The following is a description of a gene set: Alveolar rhabdomyosarcomas (ARMS) are aggressive soft-tissue sarcomas affecting children and young adults. Most ARMS tumors express the PAX3-FKHR or PAX7-FKHR (PAX-FKHR) fusion genes resulting from the t(2;13) or t(1;13) chromosomal translocations, respectively. However, up to 25% of ARMS tumors are fusion negative, making it unclear whether ARMS represent a single disease or multiple clinical and biological entities with a common phenotype. To test to what extent PAX-FKHR determine class and behavior of ARMS, we used oligonucleotide microarray expression profiling on 139 primary rhabdomyosarcoma tumors and an in vitro model. We found that ARMS tumors expressing either PAX-FKHR gene share a common expression profile distinct from fusion-negative ARMS and from the other rhabdomyosarcoma variants. We also observed that PAX-FKHR expression above a minimum level is necessary for the detection of this expression profile. Using an ectopic PAX3-FKHR and PAX7-FKHR expression model, we identified an expression signature regulated by PAX-FKHR that is specific to PAX-FKHR-positive ARMS tumors. Data mining for functional annotations of signature genes suggested a role for PAX-FKHR in regulating ARMS proliferation and differentiation. Cox regression modeling identified a subset of genes within the PAX-FKHR expression signature that segregated ARMS patients into three risk groups with 5-year overall survival estimates of 7%, 48%, and 93%. These prognostic classes were independent of conventional clinical risk factors. Our results show that PAX-FKHR dictate a specific expression signature that helps define the molecular phenotype of PAX-FKHR-positive ARMS tumors and, because it is linked with disease outcome in ARMS patients, determine tumor behavior. from publication Davicioni E, Finckenstein FG, Shahbazian V, Buckley JD, Triche TJ, Anderson MJ (PMID 16849537) studied in species Homo sapiens Human Gene Set: DAVICIONI_TARGETS_OF_PAX_FOXO1_FUSIONS_UP Genes up-regulated in RD cells (embryonal rhabdomyosarcoma, ERMS) by expression of PAX3- or PAX7-FOXO1 fusions off retroviral vectors., and this is the list of marker genes: KCNN3, PCDH7, CDH4, NRCAM, ADD1, HDAC5, YPEL5, THEMIS2, CUL3, RHOB, DKK1, TXNDC15, E2F5, PLXNC1, FST, NTAN1, DUSP1, CAV1, CSNK1E, NRP2, MYOF (myoferlin), RWDD3, PTPRE, SGK1, MSL3, SULF1, LSP1P5, MGAT5, ARHGAP29, VWA5A, MSN, ITPKB, CTSV, STK32B, FAM3C, ZNF395 (zinc finger protein 395), EMP1, P3H2, PDGFD, TCF7L1, GAS1, VEGFC, SKP2, LEPROT, SERTAD2, SATB1, NDRG1, CADM1, DDA1, RASL10A, MORC4, CARHSP1, PTPRU, HEBP1, LRPAP1, ST3GAL5, CAMK2N1, OSTF1, MYCN, HES1, SCN3B, SDC4, SPDL1 (spindle apparatus coiled-coil protein 1), MYOD1, MMD, JAKMIP2, NNMT, EYA1, ANK1, GATM, INHBA, FGGY, MAGEL2, JAK1, IGFBP6, GSDME, CHST11, CREG1, CCN1, PLAT, SCN3A, PRRX1, CAP1, CTSA, TNS3, ITM2B, KLF4, FABP5, ACKR3, TBC1D9, NID1, ID2, PCDH17, HMGCR, WSB2, ECM1, PLAU, CLMN, NCOA4, SC5D (sterol-C5-desaturase), PBK, SMAD1, CIB1, HEG1, MME, MYH9, S100A13, BCHE, FZD1, MAP3K5, HOXA11, OTULINL, DKK2, COL18A1, FGFR4, ADAMTS1, NEBL, TGIF1, LOXL2, MAFF, SH3BP5, ST6GALNAC5, PAX5, FBN2, ADAM10, TRAM2, COL6A2, MYO18A, ELK3, MET, PELI1, TIMP1, KRT18, ADAMTS5, PALM2AKAP2, FOXO1, VSTM4, IRS2, SF3B5, ANK2, THBS1, MED27, SDC2, DPY19L1, TPBG, LTBP1, ADAM19, SEPTIN6, TMEFF1, PGF, ID3, STATH (NCBI Gene Id 6779), CD9, ASS1 (argininosuccinate synthase 1), PSMD8, EPB41L4B, GPM6B, ALK, NMRK1, PCSK5, KCNS3, DTX4, PHACTR2, SUPT3H, CYBRD1, AKAP12, IL27RA, AACS, NR3C1, COL5A1, MN1 (NCBI Gene Id 4330), GADD45A, ABI1, GAD1, EPHA3, APOBEC3B, GAREM1, GATA2, GRK3, NELL1, VAV3, POU4F1, MEG3, PPP1R14B, BMP4, TNFAIP3, RHOBTB1, WBP1L, JUN, SERPINE2, PTGS1, BMP5 (NCBI Gene Id 653), FMR1, FXYD5, TCF7L2, IL4R, GPC3, TMX4, PRKAR2B, MSX2, PEA15, AUTS2, DENND2A, DCX, TSPAN8, PSEN2 (presenilin 2), PXDN, CD44, ACAT2, ERG28, GALNT10, PLSCR1, CARD10, ARRB1, INPP1, TMEM47, CREM, SOCS2, SNAI2, NUP93, S100A10, CYRIA, PCCA, AQP3, MAP1LC3B, ARID5B (AT-rich interaction domain 5B), PDGFC, MAP4K4, AP2S1, RAB32, ARF5, CD58, ARL4C, PRKCA, UGP2, ABAT, HPCAL1, MMP16, CTSC, CXCR4, CAV2, LRRC17, DIPK1A, PON2, TGFB1I1, M6PR, COL14A1, CSRP1, DDAH1, SPATS2L, NFASC, NR2F2, MARCHF3, RAP1B, DICER1, LDOC1, CCND2, TPM4